Given this list of marker genes Fads1, S100a11, Lxn, Aplp2, Gtf3a, Gfi1b, Mapk8, Nptx1, Tuba1a, Cep89, Pttg1, Fcer1a, S100a6, Smim7, Tlcd4, Rasgrp2, here is a description of the gene set: from publication Liang Y, Jansen M, Aronow B, Geiger H, Van Zant G (PMID 17220891) studied in species Mus musculus We mapped quantitative trait loci that accounted for the variation in hematopoietic stem cell (HSC) numbers between young adult C57BL/6 (B6) and DBA/2 (D2) mice. In reciprocal chromosome 3 congenic mice, introgressed D2 alleles increased HSC numbers owing to enhanced proliferation and self-renewal and reduced apoptosis, whereas B6 alleles had the opposite effects. Using oligonucleotide arrays, real-time PCR and protein blots, we identified latexin (Lxn), a gene whose differential transcription and expression was associated with the allelic differences. Expression was inversely correlated with the number of HSCs; therefore, ectopic expression of Lxn using a retroviral vector decreased stem cell population size. We identified clusters of SNPs upstream of the Lxn transcriptional start site, at least two of which are associated with potential binding sites for transcription factors regulating stem cells. Thus, promoter polymorphisms between the B6 and D2 alleles may affect Lxn gene expression and consequently influence the population size of hematopoietic stem cells. Genes changed in LSK cells (bone marrow) as a function of a QTL for the size of hematopoietic stem cell (HSC) population: comparison of reciprocal congenic strains D.B. Chr3 (DB), B.D. Chr3 (BD) and the parental strains B6 and D2. Mouse Gene Set: LIANG_HEMATOPOIESIS_STEM_CELL_NUMBER_QTL